Given this list of marker genes CLEC7A, ERRFI1, TF, IL1B, C15orf48, EEF1A1, IL6, RPL8, S100A4, LYZ, TXNIP, RPLP1, MT1F, SERPINE1, ODC1, B2M, HK2, KCNQ5, IFITM1, IFIT3, MT-ND4L, CCL3, LTBP1, RPS6, RGCC, SRGN, TMEM176A, PPP1R27, G0S2, MGST1, LGALS3, RPL5, FGL2, RPL17, OAS1, XDH, GDA, FCER1G, CAPG, PGLYRP1, IER3 (NCBI Gene Id 91950), GADD45A, CHI3L1, RPS3A (NCBI Gene Id 6189), MCEMP1 (mast cell expressed membrane protein 1), HLA-B, CCL23, RPL18A, HP, CTSH, MYBPH, MYOG, CXCR4, C1S, RACK1, RPLP0, PLAC8, RPS20, ANKRD1, S100A8, SDC4, UPP1, PROCR (protein C receptor), TSPO, GAPDH, RPL7, DMD, H3-3B, HLA-DRB1, HLA-H, CXCL2, HLA-F, RUNX1, IFI27L2, NFKBIA, RPL30, H2BC5, SOD2, S100A9, MT2A, SLPI, UCP2, PPT1, NQO1, CA3, FTH1, LRG1, RGS2, OASL, ENC1, UBD, SERPINB1, PRDX5, RPS12, GPNMB, RPS24, DEFA5, GZMK, TIMP1, ANXA1, TYROBP, TMSB4X, EEF2, NAPSA (NCBI Gene Id 9476), RPL12 (NCBI Gene Id 90679), DCLK1, EDA2R (NCBI Gene Id 60401), here is a description of the gene set: Genes up-regulated across multiple cell types from nine tissues during rat aging. studied in species Rattus norvegicus Aging causes a functional decline in tissues throughout the body that may be delayed by caloric restriction (CR). However, the cellular profiles and signatures of aging, as well as those ameliorated by CR, remain unclear. Here, we built comprehensive single-cell and single-nucleus transcriptomic atlases across various rat tissues undergoing aging and CR. CR attenuated aging-related changes in cell type composition, gene expression, and core transcriptional regulatory networks. Immune cells were increased during aging, and CR favorably reversed the aging-disturbed immune ecosystem. Computational prediction revealed that the abnormal cell-cell communication patterns observed during aging, including the excessive proinflammatory ligand-receptor interplay, were reversed by CR. Our work provides multi-tissue single-cell transcriptional landscapes associated with aging and CR in a mammal, enhances our understanding of the robustness of CR as a geroprotective intervention, and uncovers how metabolic intervention can act upon the immune system to modify the process of aging. from publication Ma S, Sun S, Geng L, Song M, Wang W, Ye Y, Ji Q, Zou Z, Wang S, He X, Li W, Esteban CR, Long X, Guo G, Chan P, Zhou Q, Belmonte JCI, Zhang W, Qu J, Liu GH (PMID 32109414) Human Gene Set: MA_RAT_AGING_UP